The following is a description of a gene set: Human Gene Set: GOBP_MYCOTOXIN_METABOLIC_PROCESS studied in species Homo sapiens The chemical reactions and pathways involving a mycotoxin, any poisonous substance produced by a fungus., and this is the list of marker genes: CYP3A5, CYP2W1, CYP3A4, AKR7A3, CYP1A2, NFE2L2, CPT1A, LCAT, CYP2A13